The following is a description of a gene set: Granulocytic hyperplasia Human Gene Set: HP_GRANULOCYTIC_HYPERPLASIA studied in species Homo sapiens, and this is the list of marker genes: IRF8, TET2, KIT, ASXL1, SRSF2, CSF3R